Given this list of marker genes Patl2, Dhx30, Lin28a, Fmr1, Mcrs1, Patl1 (NCBI Gene Id 225929), Dhx36, Aff2, Xrn1, here is a description of the gene set: Binding to a G-quadruplex RNA structure, in which groups of four guanines adopt a flat, cyclic hydrogen-bonding arrangement known as a guanine tetrad. species: Mus musculus Mouse Gene Set: GOMF_G_QUADRUPLEX_RNA_BINDING